Given this list of marker genes TUBB2B, ZNF337, ZSCAN12, CNBP, SULT2B1, PCBP3, ENTREP1, FN1, S100A2, RMND5A, RGPD8, DMD, RNF103, ZFPL1, PTPN18, here is a description of the gene set: studied in species Homo sapiens from publication Iizuka N, Oka M, Yamada-Okabe H, Mori N, Tamesa T, Okada T, Takemoto N, Sakamoto K, Hamada K, Ishitsuka H, Miyamoto T, Uchimura S, Hamamoto Y (PMID 15710396) Human Gene Set: IIZUKA_LIVER_CANCER_PROGRESSION_L0_L1_UP Using high-density oligonucleotide array, we comprehensively analyzed expression levels of genes in 50 hepatocellular carcinoma (HCC) samples with positive hepatitis C virus (HCV) serology (well (G1), moderately (G2), and poorly (G3) differentiated tumors) and 11 non-tumorous livers (L1 and L0) with and without HCV infection. We searched for discriminatory genes of transition (L0 vs. L1, L1 vs. G1, G1 vs. G2, G2 vs. G3) with a supervised learning method, and then arranged the samples by self-organizing map (SOM) with the discriminatory gene sets. The SOM arranged the five clusters on a unique sigmoidal curve in the order L0, L1, G1, G2, and G3. The sample arrangement reproduced development-related features of HCC such as p53 abnormality. Strikingly, G2 tumors without venous invasion were located closer to the G1 cluster, and most G2 tumors with venous invasion were located closer to the G3 cluster (P=0.001 by Fisher's exact test). Our present profiling data will serve as a framework to understand the relation between the development and dedifferentiation of HCC. Genes up-regulated during transition from L0 (non-tumor, not infected with HCV) to L1 (non-tumor, infected with HCV) in the development of hepatocellular carcinoma.